Given this list of marker genes Sall2, Gcg, Ddt, Cldn19, Drp2, Kcnj6, Erbb4, Itprid2, Crem, Zfp472, Pter, Slc8a1, Cadm2 (cell adhesion molecule 2), Epha7, Zfp710, Mafg, Ccdc70, Cdc27, Lin54, Shisa9, Npr3, Clic5, Zfp345, Bnc2, Psg16, Or4n5, Pde1c, Ctdspl2, Tead1, Foxp3, Pnpt1, Fat3, Amhr2, Mgat4c, Cx3cr1, Fam3c, Nrxn1, Gabrq, Ermap, Atp11c, Gria1, Vps50, Smarca1, Rab8b, Tspan2, 4930562C15Rik, Rhoa, Nphs2, Dennd5a, Ptger2, Cyp3a44, Lpin2, Man1a, Mbnl3, Akap13, Zfp966, Rbfox2, Gata6, Zfp971 (zinc finger protein 971), Wscd2, Nexmif, Raly, Ppp3r2, Gpm6a, Insyn2b, Ddx6, Dpyd, Pnpla8, Adam22, Ncr1, Mtarc1, Igf1, Wdr7, Zfp503, Zbtb10, Trio (NCBI Gene Id 77730), Slc24a2, Acot8, Nrf1, Pappa2, Dynlt5, Unc80, Pak2, Iqsec3, Adam10, Mef2c, Tnik, Ppp1r10, Nfat5, Cask (NCBI Gene Id 236691), Dtna, Chrdl1, Phactr2, Ndufaf4, Fbxo11, Sh3d19, Pcdh20, Ankrd44, Magi1, Pik3ca, Igfbp5, Septin11, Cnot9, Rngtt, Ark2c, Map1b, Zdhhc3, Ash1l, Tnfsf10, Grm4 (glutamate receptor, metabotropic 4), Nova1, Tmem252, Nlrp4b, Papolg, Unc5d, 1700028K03Rik, Zfp1005, Ppip5k2, Hoxd8, Cdk6, Igfbp2 (NCBI Gene Id 98288), 4930544G11Rik, Mip, Dio2, Etv6, Vegfa, Gm7609, Ank, Cnot1, Klkb1, Samd8, Hhip, Hoxb9, Akap6, Btnl9, Bicd1, Nptx1, Col25a1, Sh3rf1 (SH3 domain containing ring finger 1), Vipr2, Foxn2, Pla2g3, Gng2, Slc38a9, Plp1, Zfp967, AW554918, Cklf, Synj2bp, Spty2d1, Tbc1d8b, Pds5b, Dhrs9, Ptpre, here is a description of the gene set: studied in species Mus musculus Genes predicted to be targets of miRBase v22 microRNA mmu_miR_130b_5p in miRDB v6.0 with MirTarget v4 prediction scores > 80 (high confidence targets). Mouse Gene Set: MIR_130B_5P from publication Chen Y, Wang X (PMID 31504780)